Given this list of marker genes PSMC3, TRIM21, HMOX2, TKT, GSTA1, HBA1, CSNK2A2, GPX5, SESN1, STAP2, COX7A2L, PSMD14, ABCC3 (NCBI Gene Id 8714), AREG, PSMB3, GCLM, DPP3, MAFG, PSMB4, AKT2, PSMD1, SEM1, PRDX1, BLVRA, COX4I1, FABP1, GSTP1, PSMD8, ATF4 (NCBI Gene Id 468), HELZ2, NFE2L2, ALB, BRCA1 (NCBI Gene Id 672), P4HB, MUL1, GPX3, PSMA3, SKP1, IDH1, PPARA, ATP7A, CYBB, AKT1 (NCBI Gene Id 207), BACH1, NFKB1, CARM1, PSMB5, UBC, GSTA3, TXN, MT-CO3, UBA52, PSMD13, PSMD3 (proteasome 26S subunit, non-ATPase 3), SIN3A, SP1, AMER1, HBA2, CDKN2A, CREBBP, NCOR2, NUDT2, NOX4, GCLC, CCL2, PRKCI, NQO1, NCOA2, CYBA, GSR, TGS1, GPX1, HM13, PRKAA2, GPX2, PSMB6, RPS27A (NCBI Gene Id 6233), AQP8, PRKCD, MAP1LC3B, SKP2, UBXN7, ERO1A, PSMA5, PSMC2, EGF, NOX5, MED1, SIN3B, SLC7A11, PALB2, CUL3, CSNK2B, ATOX1, UBB, STAT3, RXRA, TXNRD1, KEAP1, COX7B, COX6A1, HBB, PSMD11, TBL1X, MT-CO2, COX5B, RELA, COX7C, ABCF2, NCF2, ABCC1, COX6C, PDGFA, NLRP3 (NLR family pyrin domain containing 3), HDAC3, PSMA1, COX5A, CCS, PSMC1, SOD3, CSNK2A1, SQSTM1, PRDX6, NOTCH1, PSMD2, EIF2AK3, PSMD12, TXN2, SESN2, FBXL17, PRDX2, PSMA2 (proteasome 20S subunit alpha 2), MAFK, TBL1XR1, COX6A2, BTRC, COX7A2, TXNIP, PSMC5, COX6B2, PSMA7, SRXN1, SOD1, PSMD7, NCOR1, PGD, UFD1, CAT, NPLOC4, NCF4, SOD2, EP300, NDUFA4, PSMB7, COX8C, RBX1, GPX8 (NCBI Gene Id 493869), ME1, GPX6, ABCG2 (NCBI Gene Id 9429), PSMD6, VCP, HIGD1C (HIG1 hypoxia inducible domain family member 1C), CYCS, PSMC6, COX8A, BCL2L1, G6PD (NCBI Gene Id 83159), AKT3, BCL2, PTK6, COX4I2, HMOX1, ADRM1, MYC, PRDX5, TXNRD2, PRDX3, CUL1, NCOA1, BLVRB, MT-CO1, PSMB1, NCF1, COX7A1 (cytochrome c oxidase subunit 7A1), GSK3B, CHD9, CDKN1A, PSMA6, PSMA4, SMARCD3, TALDO1, NCOA6, COX6B1, PSMB2, GPX7, PSMC4, here is a description of the gene set: studied in species Homo sapiens Human Gene Set: REACTOME_CELLULAR_RESPONSE_TO_CHEMICAL_STRESS Cellular response to chemical stress